Given this list of marker genes PRMT1, PRMT6, CARM1, PRMT5, PRMT3, PRMT8, METTL23, PRMT2, PRMT7, FBXO11, PRMT9, NDUFAF7, here is a description of the gene set: Human Gene Set: GOMF_PROTEIN_ARGININE_N_METHYLTRANSFERASE_ACTIVITY Catalysis of the reaction: S-adenosyl-L-methionine + (protein)-arginine = S-adenosyl-L-homocysteine + (protein)-N-methyl-arginine. species: Homo sapiens